The following is a description of a gene set: Cytokines mediate cell-cell communication in the immune system and represent important therapeutic targets. A myriad of studies have highlighted their central role in immune function, yet we lack a global view of the cellular responses of each immune cell type to each cytokine. To address this gap, the authors created the Immune Dictionary, a compendium of single-cell transcriptomic profiles of more than 17 immune cell types in response to each of 86 cytokines (>1,400 cytokine-cell type combinations) in mouse lymph nodes in vivo. A cytokine-centric view of the dictionary revealed that most cytokines induce highly cell-type-specific responses. For example, the inflammatory cytokine interleukin-1β induces distinct gene programmes in almost every cell type. A cell-type-centric view of the dictionary identified more than 66 cytokine-driven cellular polarization states across immune cell types, including previously uncharacterized states such as an interleukin-18-induced polyfunctional natural killer cell state. Mouse Gene Set: CUI_CDC1_FLT3L_RESPONSE_DN Genes negatively differentially expressed in cell type: cDC1 (conventional dendritic cell type 1) upon treatment with cytokine: FLT3L in mouse lymph nodes in vivo. from publication Cui A, Huang T, Li S, Ma A, Pérez JL, Sander C, Keskin DB, Wu CJ, Fraenkel E, Hacohen N (PMID 38057668) studied in species Mus musculus, and this is the list of marker genes: Ypel3, Galc, Mndal, Slc38a2 (solute carrier family 38, member 2), Sat1, Serinc3, Itm2b, Pmaip1, Ccnl1, Tbc1d4, Rgs1 (regulator of G-protein signaling 1), Tsc22d3 (NCBI Gene Id 14605), Supt4a, Klhl24, Parp8, Mxd4, Npc2, Arl5c, Trim7 (NCBI Gene Id 94089), Cd83, Pnrc1, Fuca1, Nr4a2, Tmem234, Eef2 (eukaryotic translation elongation factor 2), Dennd4a, Zfp36l1, Pid1, Btg1, Cox7a2l, Pdcd4, Rab11fip1, Tnrc6b, Ramp1, Eif3e, Btg2, Dusp1 (dual specificity phosphatase 1), Pold4